The following is a description of a gene set: T cells develop from progenitors that migrate from the bone marrow into the thymus. Thymocytes are subdivided roughly as being double negative (DN), double positive (DP), or single positive (SP), based on the expression of the CD4 and CD8 coreceptors. The DN stage is heterogeneous and can be subdivided into four distinct subsets in mice based on the expression of CD44 and CD25. In human, three distinct DN stages can be recognized: a CD34+CD38−CD1a− stage that represents the most immature thymic subset and the consecutive CD34+CD38+CD1a− and CD34+CD38+CD1a+ stages. Human DN thymocytes mature via an immature single positive (ISP CD4+) and a DP stage into CD4+ or CD8+ SP T cells that express functional T cell receptors (TCR) and that exit the thymus. In this study, gene expression was measured in each of these nine stages. studied in species Homo sapiens from publication Dik WA, Pike-Overzet K, Weerkamp F, de Ridder D, de Haas EF, Baert MR, van der Spek P, Koster EE, Reinders MJ, van Dongen JJ, Langerak AW, Staal FJ (PMID 15928199) Human Gene Set: GSE22601_IMMATURE_CD4_SINGLE_POSITIVE_VS_DOUBLE_POSITIVE_THYMOCYTE_UP Genes up-regulated in immature CD4 single positive cells versus double positive thymocytes., and this is the list of marker genes: EVC2, BAHCC1, DENND2C, CYP4B1, FA2H, CNOT6L, DEFA6, MFSD12, BMP5, EVPL, CRIM1, PRR30, IFTAP, CLEC4F, ASIC4, CST1, ANGPT4, BOC, CD1D, FUT5, DSG1, AMACR, C1QTNF1, CRNN, DLC1, BHMT, CDKN2AIPNLP1, IZUMO1R, EMILIN1, DGKK, FRS3, DCAF8L2, CHEK2, AMTN, FST, NYAP1, DHRS7B, CDHR5, DMGDH, ADAMTS16, CIBAR2, FAM209B, CDH3, SHLD1, COL20A1, APOD, AMDHD1, C16orf54, DIPK1C, CNR1, CILP (NCBI Gene Id 8483), DHRS7C, C1orf53, APOC1, ELANE, ASIC3, DLGAP3, DDX25, DNAH9, ASCL4, AP3B2, COL8A2, CCNB2, ARL4A, APLNR, APCDD1, CBFA2T3, CPXM1, CYBB, COL16A1, FDXR, EME1, LLCFC1, CELSR1 (cadherin EGF LAG seven-pass G-type receptor 1), APOL5, LINC00898, CRYBB2, PGGHG, CNKSR3, EPGN, DHX58, DNAJB8, ENPP5, ACKR4, CCDC42, CD200R1, ASIC1, AHSP (NCBI Gene Id 51327), ACTMAP, FER1L5, CABCOCO1, CFAP410, FARP1, ANKRD24, CDH12, FGFR1, C6orf58 (NCBI Gene Id 389429), INSYN2A, C22orf46P, DDX11L2, ARL6, FGR, CDO1, DQX1, BARHL2, DLK2 (delta like non-canonical Notch ligand 2), FAM181A (family with sequence similarity 181 member A), CIMIP5, BATF2, C6orf141, HEATR9, LAMP5, CYP1B1, FUT2 (NCBI Gene Id 93237), CASS4, DEPDC1B, ASAP3, B3GALT2, C4BPA, TBC1D22A-AS1, ABHD17A, LINC00649 (NCBI Gene Id 400863), ACRV1, B3GALT5-AS1, ART4, CYP27B1, DRC7, CIMIP6, SAXO2, CCDC190, EDA, CLXN, COBL, DNAJC22, DLGAP2, CDC25A, MCEMP1, EBF1, DRD2, ENPP6, PRR33, ADM2, BHMT2, CREB3L1, ABCC8, ARHGAP33, AKAP12, ADCY10, RPP38-DT, DLEC1, ADAMTSL4, ANKRD42, COL9A2, CDHR2 (NCBI Gene Id 95968), FAM180B, EFS, ADH1B (NCBI Gene Id 125), FOXI1, DSG3, METTL24, LINC00518, AGT, ADGRB3, CD226, DNAJC5B, STKLD1, FGF16, FOSL1, CNGA2, CHRNB2, ETV5, SPATA6L, LINC02868, CCDC54, CMA1, BRD7P3, CDX2, AFM, ARMCX1, EFCC1, CD1A, BPIFA3, CSTL1, ABHD17AP4, GARIN3, CCDC17, DDX31, DAB1, EPHX3, ELOVL3 (NCBI Gene Id 83401), FETUB, MYRFL, FSHR, C1R, COL4A2, FAM90A1, AHI1